The following is a description of a gene set: This event has been computationally inferred from an event that has been demonstrated in another species.<p>The inference is based on the homology mapping from PANTHER. Briefly, reactions for which all involved PhysicalEntities (in input, output and catalyst) have a mapped orthologue/paralogue (for complexes at least 75% of components must have a mapping) are inferred to the other species. species: Mus musculus electronically inferred by orthology from the curated human pathway part of: Activation of kainate receptors upon glutamate binding Reactome Pathway: Presynaptic function of Kainate receptors, and this is the list of marker genes: Gng7, Gnb5, Gng8, Gngt2, Gng3, Gng11, Gnb3, Gng5, Gnb2, Gng4, Gngt1, Gng10, Plcb3